The following is a description of a gene set: species: Mus musculus MET activates RAP1 and RAC1 Mouse Gene Set: REACTOME_MET_ACTIVATES_RAP1_AND_RAC1, and this is the list of marker genes: Dock7, Grb2, Crk, Crkl, Rac1, Gab1, Rapgef1, Rap1b, Hgf, Rap1a, Met